Given this list of marker genes CYP27B1, CKAP4, PYGL, BCAP31, TNFAIP6, TTC28, TRIM22, SERPINE1, PTPN12, MMRN2, TLR1, LILRB2, ZSCAN18, RHBDF1, CTSO, PPM1F, DDX60, GSN, TMEM41B, ATP6V1H (NCBI Gene Id 51606), ACTN1, ARHGAP22, CDA, PDE4DIP, GABARAP, CORO1C, FBXO2, FHIP2B, PSAP, NRP1, VAMP3, CTSL, RGCC, PHKG2, MFSD12, KIAA0513, RNF13, DVL2, RNASE6, SLC26A3 (solute carrier family 26 member 3), SPG21, ANG, HNMT, NPC2, TNFSF13, CEBPA, SLC29A3, HSD11B1, ARHGEF10L, KRT18 (NCBI Gene Id 3875), HLA-F, MNDA, LYN, HSPBAP1 (NCBI Gene Id 79663), CLEC7A, TSC22D1, ATP1A1, PSME2, ACP5, PLEKHO2, CYP1B1 (cytochrome P450 family 1 subfamily B member 1), COLGALT1, SPR, SYK (NCBI Gene Id 6850), SLC27A3, CYFIP1, PLK2, IFI30, ATP6AP1, CD81, HLA-DRB1, NRIP3, AVPI1, CD9, ATP6V0A1, CHI3L1, PLEK, TMEM51, SLC8B1, GM2A, PACSIN2, LIPA, CD300A, TLR2, SGK1, PRMT2, CCL18, TNS1, LILRA6, PLA2G7, LAP3, CD44, ATM, CD86, KIF1B, PI4K2A, EGR2, GPX1, PLXND1, EPB41L3, SYNPO2L, SCPEP1, MSRB1, LAMA1, SLC11A1, LRRC8B, FCGRT, QSOX1, DOCK4, IFI44, ATOX1, APLP2, GPC4, RRAS, DAB2, RREB1, GALNS, ZXDC, CRELD1, TSC22D2, SIRPA, HLA-DPB1, SAT1, HLX, RIPK2 (receptor interacting serine/threonine kinase 2), CTSS, PLPP3, ACP2, HLA-DMA, FGR, CD63, PRKCD, BACH1, CD84, BHLHE41, F3, CCL22, H2BC21, CLCN6, SPRY2, GBA1LP, NCF2, RNF130, CAND2, SPP1, IFNGR2, ITGAM, LILRA2, TFEC, CLCN7, PTPRE, GNS, TYROBP, ZNF91, FUS, ARSB, LILRB4, DSE, IFI6, CIRBP, UCHL1, PI4KA, HMOX1, CARMIL1, ZNF668, C1S, CHST15, SLC31A1, PLEKHA1, CTSB, C1QB, CDS2, ARMCX1, AIF1, LRPAP1 (LDL receptor related protein associated protein 1), LPAR6, SLC46A3, PDCD4-AS1, RIN2, NR3C2, DCAF1, ELOVL1, LPCAT3, SLC7A8, SAV1, CLEC10A, ADGRE2, EDAR, CARD9 (NCBI Gene Id 64170), LHFPL2, ARHGAP17, SYNC (syncoilin, intermediate filament protein), TBC1D1, HEXIM1, IGFBP6, PLXNB2, C1QA, ZMYND8, FNDC3B, HOMER1, here is a description of the gene set: Genes down-regulated in comparison of untreated CD25+ T effector cells at day 7 versus untreated CD25- T cells at day 7. from publication Prots I, Skapenko A, Lipsky PE, Schulze-Koops H (PMID 21347372) species: Homo sapiens Human Gene Set: GSE24634_TEFF_VS_TCONV_DAY7_IN_CULTURE_DN CD25+ regulatory T cells develop in the thymus (nTregs), but may also be generated in the periphery upon stimulation of naive CD4 T cells under appropriate conditions (iTregs). The mechanisms that regulate the generation of peripheral iTregs are largely unknown. We used microarrays to gain insights into the molecular program of extrathymic Treg development.